Given this list of marker genes GALK1, GALT, DPM3, PGM1, NUS1, SRD5A3, DPM2, GNE, MPI, PMM2, GALM, DOLK, DPM1, GALE, DHDDS (NCBI Gene Id 79947), GFPT1, here is a description of the gene set: Reactome Pathway: Diseases associated with glycosylation precursor biosynthesis part of: Diseases of glycosylation species: Homo sapiens Glycosylation diseases associated with the enzymes that mediate the biosynthesis of glycosylation precursors are curated in this section (Jaeken & Matthijs 2007, Freeze et al. 2015).